Given this list of marker genes OR56A5, OR2A42, GNAT1, OR9G4, OR4F5, PPEF1, PPEF2, OR4A47 (NCBI Gene Id 403253), OR1I1, ROM1, OR10A2, MMP24, OR2B2, SEMA5B, OR2D3, OR10AC1, OR5AK2, OR9K2, OR1G1, GRIK2, OR8D1, OR5B12, OR5M1, OR2T3, OR51A4, OR10G9, OR5BS1P, OR6F1, OR1L1, OR2T29, OR52Z1P, OR51S1, OR4F16, CA6, OR11H1, OR4Q2, OR10R2, OR51M1 (NCBI Gene Id 79479), OR52N4, TAS2R38, OR6V1, OR4M1, OR10AG1, TAS2R4, OR5AS1, OR4L1, OR4S1, OR51B6, OR10G6, OR13J1 (NCBI Gene Id 81371), OR1E1, TAS1R1, OR7A17, OR2F1, BACE1, OR8D4, TAS2R40, OR8D2, PLCB2, OR14K1, OR4A16, OR4D5, TAS2R1, OR8U9, OR6C75, OR1N2, PKD2L1, OR56A1, OR6K3, TAS2R43, OR13H1, OR8G5, OR5K3, OR8S1, REEP6, CRB1, OR52N2, OR52M1, CST2, OR2T6, OR4K3, OR51G2, OR6N1, CNGB1, OR8G2P, OR9Q2, OR51C1P, FYN, OR4F29, OR52A5, PJVK, OR5L2, TAS2R20, OR4E2, OR10A6, OR13G1, OR7C1, TAS2R14, OR52R1, OR2F2, OR4X1, OR52N1, OR10P1, TAS2R16, SCN1A, OR14I1, OR2AE1, OR5T3, OR10V1, OR2T1, TAS2R46, ATP8A2, OR8K3 (NCBI Gene Id 81167), OR1C1, OR4C6, OR2T33, OR5F1, TAS2R9, OR4A8, CST1, OR13C3, OR51A7, OR8B8, OR51E1, TAS2R30, WHRN, OR2G2, OR1J2, OR2M7, GNAT3, OR56B2P, OR10J1, OR10J3, OR5J2, OR2M2, OR6C1, OR4A4P, OR10Z1, SCN11A, OR7G1, OR6K2, OR7E24, OR2T27, OR51I1, OR2Y1, TAS2R5, OR2AJ1, OR14A2 (olfactory receptor family 14 subfamily A member 2), OR51L1, OR5H6, OR6B1, TAS2R8, OR1D4, OR52L1, OR4F4, MKKS, OR6K6, OR52A1, OR52E1, OR13C4, OR2A4, OR4D10, OR1F2P, OR13A1, OR10A5, OR6A2, OR7G2, OR12D2, OR52N5 (NCBI Gene Id 81249), OR2J3, OR51V1, CACNA1F, TAS1R2, OR5AC2, OR2W1, ADORA1, OR2T35, OR51B2, OR5A1, OR4C12, OR2I1P, OR2A7, OR51T1, OR2AG1, WDR47, OR52E2, OR4F3, OR2A2, OR6Q1, STRC, OR1K1, OR2T11, OR7A5, COMT (NCBI Gene Id 1312), OR52H1, OR51G1, OR5D16, TAS2R60, RTP4, OR2T4, TAC4, OR2S2, OR8H3, OR5K2 (NCBI Gene Id 79288), OR13C7 (olfactory receptor family 13 subfamily C member 7 (gene/pseudogene)), OR10K2, OR52A4P, OR5K4, OR2L8, OR10T2, OR1J4, KCNK2, ITGA2, OR6X1, OR5H1, OR52B2, OR6C2, OR8U1, OR2AP1, CACNA2D4, OR2H1, OR1F1, OR2T7, OR5AR1, OR4X2, OR13C2, OR2B8P, OR10H3, OR8A1, OR2C1, OR12D1, OR10H4, OR10X1, OR6P1, OR10D3, OR2M5, OR2W6P, OR1L4, OR51E2, OR10J5, OR52I1, NTSR1, OR4C45, PRPH2, OR8J1, OR5M3, OR6T1, OR5V1, RGS9BP, OR8K1, OR8I2, OR8H2, TRPV1, OR2T10, OR4S2, OR4C16, OR6C70, OR4P4, NTRK1, OR7C2, OR10J6P, OR5M8, OR10G2, TMC1, OR1L8, OR5D14, OR4D1, OR5AC1, TMEM120A, OR10K1, OR14C36, ADGRV1, OR52L2P, OR4M2, OR4K13, OR5I1, GUCY2F, OR1E3, OR6B2, OR8U3, OR51F2, OR2T12, OR1D2 (NCBI Gene Id 4991), OR5L1, LXN, OR2H2 (NCBI Gene Id 7932), CCDC66, OR4D6, OR51F1, LPO, RTP5, OR1F12P, OR13F1, OR3A1, OR4A15, TAS1R3, OR1J1, TAS2R7, CXCL12, OR2W5P, OR2A14, OR5M11, OR2A12, OR9Q1, OR4F15, BEST1, OR5D13, RBP4, OR4C11, OR2B11, OR6N2, OR13D1, OR52E5, OR4C5, TAS2R19, OR5AN1, OR9A4, OR8B4, OR5H2, OR10H1, OR10S1, SCN9A, OR8B3, OR6C74, TAS2R45, OR2AK2, OR4D11, OR6B3, OR5B17, MYC (NCBI Gene Id 731404), OR3A3, OR2M4, OR11H4, OR2A1, OR4A5, OR1Q1, OR4C46, OR4K2, LHFPL5, OR9G1, OR7A2P, OR52K1, OR11H2, OR2G6, OR11H12, OR5T1, OR4Q3, OR4F21, EPHB1, GPR148, OR4D2, ASIC3, TAS2R39, OR52D1, OR51I2, OR5B2, PIP, PDZD7, OR11A1, OR10H5, OR1P1, OR51J1, TRPA1, OR13C5, TAS2R50, OR5B3, OR4K14, FFAR4, OR4N4, OR51B5, OR13C6P, OR5AU1, KCNK4, TMEM87A, RHO, COL11A1, OR2L3, OR4N5, OR4C13, OR14L1, OR5M9, OR5D18, OR2J1, OR13C9, OR4M2B, OR10A4, OR2Z1, OR3A2, OR1L6, OR2M3, OR7A10, OR4K15, OR6Y1, PRDM12, OR4C3, OR5AL1, OR6M1, KCNQ1, OR8B12 (olfactory receptor family 8 subfamily B member 12), PTPRQ, OR1N1, OR4D9, OR8G1, OR5AP2, TAS2R42, OR7G3, OR8U8, OR10AD1, OR11L1, OR2B6, OR11H6, OR10G7, OR1A1, OR1D5, OR6C6, OR5AK3P, OR5B21, OR5C1, OR1S2, OR5K1, OR2L5, OR5H8, OR2T8, TULP1, OR10W1, TAS2R13, OR4E1, OR9A1P, OR2B3, OR6J1 (NCBI Gene Id 79549), OR5W2, OR52E6 (NCBI Gene Id 81265), SLC24A4, OR51D1, OR13C8, OR14A16, OR9I1, OR1L3, AZGP1, OR8K5, TAS2R31, OR1S1, KCNA1, TMC2, OPN4, OR56B1, OR8G3P, TNF, OR52W1, OR11H7, OR4F6, CHRNA10, OR4N2, OR10D4P, DISC1, OR2W3, OR5H14, OR10Q1, OR2L13, OR4K5, OR4B1, RPE65, OR2K2, OR10C1, OR1A2, OR2D2 (NCBI Gene Id 8597), OR52I2, OR56A3, OR2T34, RTP3, OR5T2, OR1M1, CST4, OR51A2, OR10G8, OR2AG2, OR56B4, OR51B4, OR12D3, OR6C76, OR6S1, OR2C3, OR8J2, OR52B6, OR2V1, OR7D2, OR2J2, OR10A7, OR52P1, PIGR, PHF24, SERPINE2, OR2A25 (olfactory receptor family 2 subfamily A member 25), OR5A2, OR1E2, OR1B1, OR52E4, OR52K2, OR5P2, HTR2A, OR2AT4, PKD1L3 (NCBI Gene Id 342372), OR5M10, RTP2, OR2L2, OR52E8, SCRN3, GNAT2, NR2F6, OR6C65, OR56A4, OR2T2, PIEZO2, OR2V2, OR52J3, OR11G2, OR10G4, OR52B4, OR8J3, OR14J1, OR5G3, TAS2R10, ANO1, CHRNA9, OR2G3, HPN, OR2T5, OR9G9, OR10G3, OR6C3, OR9A2, OR6C68, EYS, OR51Q1, RTP1, OR4K17, ASIC2, OR8B2, REST, TAC1, KIT, OR8H1, OR5P3, OR51H1, OR10H2, OR10A3, OR5H15, TAS2R3, CACNB4, OR4C15, TAS2R41, OR2A5, OR4K1, GRM6, OR10J4, CEP250 (NCBI Gene Id 11190), OR7D4, GJA10, OR4F17, OR6C4, here is a description of the gene set: Human Gene Set: GOBP_DETECTION_OF_STIMULUS_INVOLVED_IN_SENSORY_PERCEPTION The series of events involved in sensory perception in which a sensory stimulus is received and converted into a molecular signal. studied in species Homo sapiens